Given this list of marker genes CELA2A, ERCC6, ABCA1, SERPIND1, LRP6, PCSK9, PRKG1, ABCG8, SMAD2, PPP1R17, ESR1, FOXE3, ZNF687, APOA2, TGFB3, APOB, TGFBR2, ELN, TGFB2, MYH11, CYP7A1, ERCC8, BRCC3, CEP19, LDLR, PNPLA2, MEF2A, APOE, ABCG5, SMAD4, LMNA, THSD4, PPARG, SMPD1, FBN1, MYLK, LIPC, SMAD3, MAT2A, GPIHBP1, APOA1, LDLRAP1, GHR, ACTA2, LOX, XYLT2, TGFBR1, ABCC6, MFAP5, HEY2, EPHX2, XYLT1, CYP27A1, here is a description of the gene set: Coronary artery atherosclerosis studied in species Homo sapiens Reduction of the diameter of the coronary arteries as the result of an accumulation of atheromatous plaques within the walls of the coronary arteries, which increases the risk of myocardial ischemia. Human Gene Set: HP_CORONARY_ARTERY_ATHEROSCLEROSIS